Given this list of marker genes LRP6, PPP1R15B, FGFR1, HUWE1, RPS6KA3, MSX1, BCOR, TSPEAR (thrombospondin type laminin G domain and EAR repeats), SH3BP2, ATP6V1B2, KDM6A, CUX1, KIFBP (NCBI Gene Id 96724), PTHLH, KCNJ2, WNT5A, SMOC2, PUM1 (pumilio RNA binding family member 1), UBR1, AXIN2, CLDN1, SRCAP, KCNJ5, ANKRD11, NEPRO, PAX9, HNRNPK, KREMEN1, DVL3, CEP152, PITX2 (paired like homeodomain 2), TGFA, MAP3K7, TRMT10A, TRIO, POLR3GL, BCL11B, KMT2D, POLR3A, EDARADD, DVL1, WNT10A, LTBP3, EDA, PIK3C2A, RHOA, IRF6 (interferon regulatory factor 6), POLR3B, FLNA (NCBI Gene Id 8272), SCUBE3 (signal peptide, CUB domain and EGF like domain containing 3), EDAR, SATB2, SUMO1, IKBKG, CCBE1, CHSY1, PORCN, SLC25A24, ADNP, MAF, WNT10B, TP63, SRD5A3, FZD2, PTH1R, here is a description of the gene set: The absence of six or more teeth from the normal series by a failure to develop. Human Gene Set: HP_OLIGODONTIA studied in species Homo sapiens Oligodontia